Given this list of marker genes Ddrgk1, Cnot2, Lats1, Src, Cnot3, Pou4f2, Ufsp2, Wbp2, Foxh1, Ar, Cyp7b1, Esr2, Esr1, Vps18, Ufm1, Ncoa3, Cnot1, Padi2 (peptidyl arginine deiminase, type II), Brca1, Trip4, Rbfox2, Isl1, Pagr1a, Foxa1, Arid1a, Pak1, Parp1, Taf7, Dnaaf4, Kank2, Skp2, Gper1, Vps11, Trp63, Lbh, Zfp366, Srarp, Fshr, Ufl1, Ppargc1b, Strn3, Cnot9, Ncoa1, Uba5 (ubiquitin-like modifier activating enzyme 5), Kmt2d, Safb, Ddx5 (DEAD box helicase 5), Med1, Phb2, Ddx17, Carm1, here is a description of the gene set: studied in species Mus musculus Mouse Gene Set: GOBP_ESTROGEN_RECEPTOR_SIGNALING_PATHWAY A nuclear receptor-mediated signaling pathway initiated by an estrogen binding to an intracellular receptor of the nuclear receptor protein family, and ending with regulation of a downstream cellular process, e.g. transcription.